The following is a description of a gene set: studied in species Mus musculus Mouse Gene Set: chr4C7, and this is the list of marker genes: Gm22345, 4933424M12Rik, 4930522H14Rik, Gm12728, Magoh, Cdkn2c, Gm12743 (NCBI Gene Id 115489936), Dmrta2, 4930407G08Rik, Echdc2, Pcsk9, Gm23138, Gm12738, Cpt2, Cdcp2, Pars2, Gm22497, Gm12803, Zyg11a, Ttc39aos1, Tceanc2, Coa7, Gm12802, Mrpl37, Slc1a7, Hspd1-ps4, Ttc4, Nrdc, Ndc1, Scp2, Shisal2a, Calr4, Eps15, Czib, Gpx7 (glutathione peroxidase 7), Acot11, Gm12740, Gm12727, Dmrta2os, Zyg11b, Gm12742 (predicted gene 12742), Tmem59, Gm12870, 9630013D21Rik, Ldlrad1, Orc1, Mroh7, Gm12739, Rab3b (NCBI Gene Id 69908), 8030443G20Rik, Mir6397, Gm12749, Gm12724, Glis1, Kti12, Lrp8os3, Gm12786, Lrrc42, Btf3l4, Gm12907, Usp24, Ttc22, Podn, Prpf38a, Ttc39a, Gm12807, Gm25827, 1700047F07Rik, Ssbp3, Gm12729, Cc2d1b, Lrp8os1, Rnf11, Lrp8, Tmem61, Gm26047, Gm12741, Mir761, Cimap2 (NCBI Gene Id 242602), Elavl4, Faf1, Yipf1, 2700068H02Rik, Txndc12, Cyb5rl, Bsnd, Agbl4, Dhcr24, Lrp8os2, Gm12899, Fam151a, Gm23354, Osbpl9, Gm12906, Zfyve9, Ift25, Dmrtb1, Tut4 (NCBI Gene Id 320841), Dio1